The following is a description of a gene set: Human Gene Set: WP_ERK_PATHWAY_IN_HUNTINGTONS_DISEASE ERK pathway in Huntington's disease species: Homo sapiens, and this is the list of marker genes: CREB1, MAPK1, EGF, MAP2K2, GRM1, CASP7, ELK1, MAPK3, RPS6KA5, HRAS (NCBI Gene Id 338029), HTT, NTRK2, BDNF, MAP2K1, CASP3, EGFR, RAF1